The following is a description of a gene set: Mouse Gene Set: REACTOME_KERATAN_SULFATE_DEGRADATION Keratan sulfate degradation studied in species Mus musculus, and this is the list of marker genes: Glb1l3, Galns, Hexa, Gns, Prelp, Acan, Fmod, Glb1l2, Hexb, Glb1l, Glb1, Kera, Lum, Ogn, Omd